Given this list of marker genes Polr1g, Taf1b, Lipe, Smarcb1, Rrn3, Polr1e, Cavin1, Ubtf, Tbp, Taf1c, Ttf1, here is a description of the gene set: A transcription initiation process that takes place at a RNA polymerase I gene promoter. Ribosomal RNAs (rRNA) genes are transcribed by RNA polymerase I. studied in species Mus musculus Mouse Gene Set: GOBP_TRANSCRIPTION_INITIATION_AT_RNA_POLYMERASE_I_PROMOTER